Given this list of marker genes RN7SK, HBEGF, ANAPC7, NDUFA9, H2AZ2 (H2A.Z variant histone 2), TXNL4A, EIF3K, MYOT, PGAM1, ZP1, KCTD5, HNRNPA3, RTKN, ATP5MF, POP7, ITPRIPL1, GNA13, SLBP, VAMP8, STRN, GIMAP1, BRD9, GPD1L, EEF1B2, EEF1D, MXD1, NUP54, SUCLG2, TIMM17A, RRM1, TNFRSF9, ZBBX, ATP6V0D2 (ATPase H+ transporting V0 subunit d2), C18orf32, TOP2A, LSM4, COX5A (cytochrome c oxidase subunit 5A), USP44, TRMT10A, ITGAV, RPL11, ITGA5, CORO2B, KLF10, OCIAD1, SCGB1C1, DESI1, ATP6V1A, LAMTOR5, WHRN, TEX101, MSLN, SDHB, NDUFA4, CKB, IL10RA, RELL1, LPIN1, PHF5A, ST3GAL5, RPLP1, PSMB9, KIF11, FAU, ZMYND8, ABHD14A, MAGEE1, NT5C, SLC43A1, MVD, MRPL15, SMYD1, TRAM1, AGPAT4, CLPTM1, TIMM10, PSMB3, PFDN6, UQCRH, TBCB, TSPAN13, CPM (NCBI Gene Id 1368), GLT8D2, ATF7IP2, EIF3I, DAD1, CNPY2, H2BC14, JOSD2, MIER3, ISLR, CENPA, CNBP, H2BL1P, RILPL2, RPL10A, PTPRVP, TOP1 (NCBI Gene Id 7150), H4C3, ACADL, DNAAF4, CPT2, TXNRD1, SOD1, POLR1C, S100A6, KDM8, SPCS1 (signal peptidase complex subunit 1), TASP1, FOS, LANCL1, RAB7A, MIR665 (microRNA 665), PSME3IP1, FNDC8, AP2S1, MRPL36, ERO1A, DPH2, SMPX, MFSD14B, SNRPD1, FOSB, SDE2, PIGV, TAS1R2, PGPEP1L, QDPR, STMN1, UNC119B, EIF4EBP1, MYH7, BSPRY, MAGED2, SPAG5, CDK6, DUSP5, GALNT13, RPS3, NHP2, MIR30A (NCBI Gene Id 407029), HMMR, VARS1, PGAP2, SHCBP1, LYRM2, CERK, MPC1, PTMA, NSA2, KLRG1, CASP3, ASB1, SH3TC2 (SH3 domain and tetratricopeptide repeats 2), XRCC6, here is a description of the gene set: Human Gene Set: GSE10500_ARTHRITIC_SYNOVIAL_FLUID_VS_HEALTHY_MACROPHAGE_UP studied in species Homo sapiens Macrophages from RA synovial fluids were compared to primary human blood-derived macrophages. from publication Yarilina A, Park-Min KH, Antoniv T, Hu X, Ivashkiv LB (PMID 18345002) Genes up-regulated in macrophages from patients with synovial fluid rheumatoid arthritis versus monocyte-derived macrophages from healthy persons.